The following is a description of a gene set: Any microtubule that is part of a mitotic spindle; anchored at one spindle pole. Mouse Gene Set: GOCC_MITOTIC_SPINDLE_MICROTUBULE studied in species Mus musculus, and this is the list of marker genes: Cltc, Haus8, Haus6, Haus3, Cep295 (NCBI Gene Id 399598), Haus1, Hnrnpu, Eml3, Haus5, Tubg1, Mapre1, Haus2, Map1s, Haus7 (HAUS augmin-like complex, subunit 7), Haus4